Given this list of marker genes Bmp7, Six1, Stat1, Tcf21, Myc, Wnt4, Wt1, Six2, Amer1, Shh, Pkd2, Six4, Osr1, Smad4, Pax2, Foxd1, here is a description of the gene set: studied in species Mus musculus Mouse Gene Set: GOBP_KIDNEY_MESENCHYME_DEVELOPMENT The biological process whose specific outcome is the progression of a kidney mesenchyme from an initial condition to its mature state. This process begins with the formation of kidney mesenchyme and ends with the mature structure. Kidney mesenchyme is the tissue made up of loosely connected mesenchymal cells in the kidney.